The following is a description of a gene set: Human Gene Set: chr20p13 species: Homo sapiens, and this is the list of marker genes: TBC1D20, RPS10P5, PRNP, ADISSP, ZCCHC3, ANGPT4, RPS21P7, DEFB132, SNRPB (small nuclear ribonucleoprotein polypeptides B and B1), CSNK2A1, LZTS3, PCED1A, ADRA1D, IDH3B-DT, DEFB127, SNPH, PSMF1 (NCBI Gene Id 9491), ZNF343, ENSG00000305741, RAD21L1, RNF24, SLC52A3, TMEM239, DEFB128, ADAM33, RPL21P2, UBOX5-AS1, AP5S1 (adaptor related protein complex 5 subunit sigma 1), PTPRA, STK35, RN7SL561P, PDYN, SNORD86, OXT, ACTG1P3, SCRT2, C20orf202, SF3A3P1 (NCBI Gene Id 170548), SIRPA, TRIB3, SNORD110, NOP56 (NOP56 ribonucleoprotein), SIRPD, MIR103A2, TVP23BP3, SLC4A11, NRSN2-AS1, ENSG00000306995, ENSG00000201346, NSFL1C, SOX12 (SRY-box transcription factor 12), EBF4, CDC25B, RNU6-1019P, SLC23A2, TMEM74B, RASSF2, MIR1292, SDCBP2, SMOX, DEFB126, DEFB129, IDH3B, PDYN-AS1, CENPB, MIR6869, UBE2V1P1, RN7SL555P (RNA, 7SL, cytoplasmic 555, pseudogene), SNORD57, GNRH2, GFRA4, SIGLEC1, PANK2, UBOX5, RNA5SP474, RSPO4, CKAP2LP1, NRSN2, RBCK1, ENSG00000303036, ATRN, FASTKD5, ENSG00000294501, ENSG00000286288, SIRPB2, FAM110A, SDCBP2-AS1, TMC2, SPEF1, HSPA12B, MAVS, FTLP3, TGM3, MIR103B2, VPS16, IDI1P3, C20orf96, SIRPG, ITPA, DEFB125, SIRPG-AS1, DNAAF9, SIRPB3P, SRXN1, PANK2-AS1, AVP, LINC03086, TGM6, SNORA51 (NCBI Gene Id 677831), C20orf141, CPXM1, MRPS26, TCF15, RPL7P2, LINC01730, PRNT, FKBP1A, SIRPB1, PRND, DDRGK1, LINC01433, RPL19P1, RPS4XP2, RPL7AP12, RNU6-917P, SNORD56, TCEAL9P1 (TCEAL9 pseudogene 1)